The following is a description of a gene set: A compartment that consists of a lumen and an enclosing membrane, and is part of an organelle. studied in species Mus musculus Mouse Gene Set: GOCC_ORGANELLE_SUBCOMPARTMENT, and this is the list of marker genes: Slc35b1, Ugt1a2, AU040320, Hsd3b7, Fitm2, Vma21, Arxes1, Pik3r1 (NCBI Gene Id 328326), Alox5ap, Get1, Lmf1, Hsd3b3, Pigz (phosphatidylinositol glycan anchor biosynthesis, class Z), Cyp2a5, Marchf8, Ergic3, Eif2ak3, Vps53, Cyp1a1, Arfip1, Pheta1, Igf2r, Alg2, Emc6, Mtdh, Cyp2c55, Trappc6a, Faxdc2, Trappc9 (trafficking protein particle complex 9), Tbc1d23, Pi4k2b, Pip4k2b, Ptgs2, Pnldc1, Vrk1, Rpl27, Trex1, Hmox1, Golga2, Uba5, Rdh16, Agpat2, Tmed5 (NCBI Gene Id 74336), Atp8b1, Hpn, Dop1b, Ugt1a6a, Fads2, Atp6ap1, Clvs1, Sacm1l (NCBI Gene Id 83493), Disp3, Abhd12b, Rab11fip3, Fut2, Pacsin3, Ergic1, Gbf1, Cybc1, Slc37a2, Dhcr24, Por, Chrm3, Pmel, Sgpp1, Lgr5, Cyb5rl, Hsd17b3, Traf3ip3, Rab29, Slc9a7, Slc18a1, Vrk2, Pkmyt1, Cyp2c38, Cyp4a10, Gcc2, Kpnb1, Cyp7b1, Trim59, Alg12, Slc11a2, Mbtps2, Cherp, Stimate, Pomgnt2, Reep4, Mr1, Pja2, Rtcb, Pigo, Nat8f4, Sec11a, Sar1b, Tbc1d20, Dlg1, Hacd2, Or10j5, Cyp4a14, Ap3s1, Iigp1, Reep6, Zdhhc6, Rab31, Tmem50b, Rtp1, Gnai3, Dnajc1, Hace1, Akap6, Mgst1, Ext1 (exostosin glycosyltransferase 1), Mbtps1, Ttyh1, Jagn1, Sec31a, Rft1, Sec23a, Vapb, Cyp17a1, Snx9, Gpat4, Clip3, Rab38, Ap1s3, Inpp5e, Gba2, Tm7sf2, Smpd5, Gdpd1, Atxn3, Yipf6, Plpp7, Ap1g1, Parp6, Cog3, Retreg1, Sec61bl, H2-Q7, Stt3b, Otulinl, Sgk1, Eif5a, Slc37a1, Arhgap32, F830016B08Rik, Tmc6, Ei24, Preb, Icmt, Syvn1, Gimap3, Rab9, Tmem63c, Slc37a3, Ndst1, Gga1, Rnf139, 9930111J21Rik1, Lyset, Arl6ip1, Mlec, Atp8a2, Cers6, Ptgs1, Zdhhc12, Lman1l, Uchl1 (NCBI Gene Id 97283), Tmcc1, Slc27a1, Stard3, Rnf19b, Slc30a5, H2-T23, Rab2a, Sec1, Cyp2e1, H2-D1, Tmem201 (NCBI Gene Id 52277), Zfyve1, B4galt7, Aldh3a2, Irag2, Rheb, Frrs1l, Erlin1, Atp8b5, Scamp3, Rgs20, Bace1, Lss, Cdipt, Rab2b, Reep5, Bnip3, Golph3l, Cideb, Eva1a (NCBI Gene Id 232146), Galnt3, Mob4, Rhbdf1, Sts, Alg3, Ica1, Pld6, Lman1, Alg10b, Nat8f2 (NCBI Gene Id 93673), Ihh, Emd, Pnpla8, Pign, Adam10, Nucb1, Lyz1, Ndrg4, Tmem43, Kdelr3, Ubxn8, Fmo1, Atp8b4, Rnf133, Hhatl, Wdr11, Tmem87a, Dpy30, Or5b21, Agpat1, Cftr, Cdh1, Tmed1, Hsd3b4, Gramd1b, Bax, Tmcc2, Fut1, Fzd9, Ssr4, 4930568D16Rik, Sptssa, Ms4a7, M6pr, Dgat2l6, Nagpa, Derl3, Ufl1, Rnf26rt, Card19, Ksr1, Yipf1, Ermp1, Bscl2, Gpr89, Lpin2, Klhl41, Pln, 5730455P16Rik, Mrln, Dnaaf6, Slc35b2, Fkbp1a, Slc35d1, Mmp23, Kdelr2, Fut11, Kdelr1, Yipf4, Ptdss2, Sik2, Flrt3, Atg9a, Rps28, Pigk, Arfgef2, Osbp, Pacsin1, Flrt1, Saraf, Cyb5r3, Arl5c, Lyz2, Cyp2d11, Tmem14a, Slmap, Art1, Gm5431, Rnf185, Sec61g, Erlin2 (NCBI Gene Id 97480), Nos1ap, Rpn2, Mrap, Mgat4b, Acsl3, Degs1, Oas1b, Zdhhc20, Alg13, Tmem178, Pnpla6, Dgat1, Usp17lb, Pdia3, Aftph (NCBI Gene Id 75762), Golga1, Rint1, Tmem199, Tapbp, Sigmar1, Dnaaf6rt, Ms4a6c, Pcyt1a, Plod3, Tmem129, Rnf125, Chst5, Tespa1, Tspo2, Pkd2, Pcsk5, H2-T3, Cimap3, Retsat, Ntsr2, Slc9a8, Oca2, Cyp2c37, Egfr, Dhcr7, Nploc4 (NPL4 homolog, ubiquitin recognition factor), Cds1, Mgat4a, Usp17lc, Ccdc47, Calr3, Abcb6, Bicd1 (BICD cargo adaptor 1), Sez6l, Gm12185, Bet1l, Ube2j1, Cyp1a2 (NCBI Gene Id 13077), Atp13a4, Ugt1a1, Tmem119, Zdhhc14, St3gal1, Atp2a1, Cyp7a1, Atp6ap2, Gpsm1, Atp7b (NCBI Gene Id 11979), Jkamp (NCBI Gene Id 70280), Saysd1, Spcs2, Atp8b3, Tmem41b, Slc39a13, Golga3, Rab30, Grin2b, Golph3, Pacsin2, Cyp2d9, Pigl, Ncln, Ern2, Dpagt1, Dhh, Rnf183, Srd5a1, Tmem38b, Rdh19, B4galt6, Ap3b2, Hmgcr, H2-Q6, Flvcr2, Cyp2d10, Vkorc1l1, Dpy19l3, Atp13a1, H2-Q4, Tmem151a, Slc36a2, Csgalnact2, Sec11c, Tap1, Lclat1, Izumo1, Hook2, Esyt3, Extl2, Cnih1, Tgfbi, Mapkap1, Fdft1, Znrf4 (NCBI Gene Id 73546), Vps13c, Ssr1, Nr3c2, Fmo2, Rpe65, Spink5, Dipk1c, Sec22c, Epm2a, Zdhhc1, Tmed9, Selenot, Gga2, Ktn1, Yif1b, Gosr1, Hspd1, Slc33a1 (NCBI Gene Id 99713), Rps29, Prkd1, Vamp4, Vps51, Tmem86b, Akap9, Slc27a5, Arfip2, Reep3, Ankrd13c, Scd4, Pdzd8, Ap1s1, Snap25, Clcn4, Atp7a, Dnajc16, Tkt, Arf1, Galnt2, Cyp4f39, Dad1, Ankle2, Suco, Nfe2l1, Ormdl2, Sort1, Neu4, Mgst2, Mboat2, Rac1, Pcsk1, Slc17a3, Ncstn, Pitpnm1, Rab27b, Emc1, Stx16, Txndc11, Cept1, Serp1, Car4, Asph, Atp10d, Gramd1a, Aadac, Fads2b, Tmem147, Alg8, Lnpk, Zc3h12a, Tmem98, Atp2c2, Atp10a, Agpat5, Tmem79, Cyp2b19, Scamp4, Gba1, Reep2, Lypla2 (NCBI Gene Id 26394), Tgoln1, Pofut2, Tmem230, Tecr, Tgtp1, Bcap29, Slc10a7, Mboat7, Tmem260, Pigf, Dcstamp, Dgat2, Sc5d, Chpt1, Or7a40, Srebf1, Tepsin, Nsfl1c, Hid1, Clgn, Mymx, Kif13a (kinesin family member 13A), Atp8a1, Stard3nl, Cspg5, Scfd1, Lmbr1l, Jph1 (NCBI Gene Id 57339), Ap4s1, Ano5, Irgm1, Tmprss3, Rasgrf2, Cd2ap, Hsd17b12, Bace2, Get3, Plekhj1 (pleckstrin homology domain containing, family J member 1), Arl5b, Glg1 (NCBI Gene Id 20340), Extl1, Tpte, Agmo, Awat1, Mgat2, Ostc, Fate1, St3gal3, Sppl2c, Fam91a1, Rdh1, Zfand2b, Afg2b, Pigw, Cyp2c39, Pcsk7, Becn1, Slc8a3, Piezo1 (NCBI Gene Id 234839), Lrit1, Shisa2, Cyp4f14, Atp11a, Smim14, Rtn4, Elovl6, Psen2, Slc35b3, Dipk1b, Ubxn1, Tmx1, Dhdds, Piga, Ugt1a7c, Plpp2, Shisa3, Mospd2, Scd2, Tmem68, Minar2, Arv1, B4galt5, Fmo5, Usp19, Tram1l1, Hsd3b1, Cln3 (CLN3 lysosomal/endosomal transmembrane protein, battenin), Pigt, Ptgis, Scoc, Mgat4d, Acsl5, Ilvbl, Rnf43, Lrit3, Cers3, Hsp90b1, Ryr2, Spcs3, P2rx6, Ap3d1 (NCBI Gene Id 11776), Pml, Pdcd6, Osbpl3, Slc30a6, Plekha3, Dtnbp1, Fa2h, Osbpl8, Abcd4, Chpf, Clcc1 (chloride channel CLIC-like 1), Grn, Cisd2, Xxylt1, Ctdnep1, Agtrap, Gpaa1, Tom1l1, Myrf, Dnajb12, Tmed11, Calr, Msmo1, Ocrl, Irgm2, Nsg1, Zdhhc16, Sgpp2, Nat8l, Mia3, Ufd1, Cyp21a1, Emc4, Selenok, Ubiad1, Sgms1, Rnf26, Tmem258, Stim1, Panx3, Rab18, BC016579, Smim6, Sec24a, Pld5 (NCBI Gene Id 319455), Hacd1, Fut10, Gsap, Gal3st3, Grin1, Emc3, Slc2a4, Csgalnact1, Ddrgk1, Tmem174, Rtn3 (reticulon 3), Fmn1, Klhl14, Cers2, Ap4m1, Uba1, Rab3gap1, Bsg, Mogat1, Faf2, Parp16, Sting1, Selenos, Rpn1, Alg9 (NCBI Gene Id 77986), Rnf170, B4galnt4, Psen1, Fkbp1b, H2-Q1, Ero1a, Rdh9, Samd8, Trappc4, Clstn2, Sulf1, Ift88, Sqle, Ubxn4, Jph3, Atf6b, Ric3, Cyp2c29, Ugt3a1, Scamp1, Pik3c2a, Cln8, Hmgcll1, Map3k5, Hsd17b7, Pld1, Ap4b1, Tmem109, Mblac2, Tmc8, Nat8, Aldob, Maco1, Tpst1, Acer1, Fads3, Cpt1c, Myrfl, Tmed2, Sorl1, Grm6, Tmbim4, Itpr1 (inositol 1,4,5-trisphosphate receptor 1), Cers4, Scamp2, H2-Q2, Rce1, Cyp2j5, Tram2, Cpd, Myorg, Atp2a2, Stx8, Cyp26b1, Rps26, Ap1b1, Tgtp2, Wipi1, Slc30a1, Cyp3a41a, Ern1, Ccdc186, Notch1, Extl3, Aup1, Sec31b, Emc8, Tmed10, Cyp2c54, Arfrp1, Tmx3, Cyp3a25, Vmp1, Gm12250, Atp2a3, Atxn2 (ataxin 2), Pld4, Pitpnb (NCBI Gene Id 56305), St6gal1, Awat2, Erg28, Sec61a2, Cyp3a16, Apoo, Dnajb2, Srd5a2, Tmem238l, Nbea, Pex16, Slc27a6, Eda (NCBI Gene Id 13607), Hacd3, Cnih4, Tmem165, Marchf4, Ugt1a9, Nomo1, Elovl2, Sec63, Nucb2, Chst2, Jph4, Fads1, Inpp5k, Prss56, Ost4, Dmpk, Atp9a, Rnf180, Ergic2, Cd74, Marchf5, Ubqln4, Tmed3, Phtf1, Yipf5 (NCBI Gene Id 67180), Dnm2, Vps54, Bet1, Lpin1, Dhrs7, H2-K1, Sec16a, Slc39a9, Bsn, Atg14, Zdhhc2, Dnajb14, Cyp4v3, Yipf2, Cyp4b1, Ephx1, Dhrs9, Tram1, Cyp3a44, Cyp8b1, Creb3l4, Peds1, Trdn (triadin), Scap, Tmem106c, Bltp2, Usp17le, Tex2, Mmp27, Zdhhc9, Atg9b, Tmem208, Mapk8ip1, Tmed6, Slc35g1, Osbpl6, Cyp2c50, Dpy19l1, Rnf145, Gimap1, Slc39a1, Gramd2a, Pcsk4, Fmo3, Cyp4a12b, Stx18, Hsd3b6, Tlr9, Tab1, Panx2, Nat8f1, Jph2, Sln, Bok, Dhrs7b, Acsl4, Ddost (NCBI Gene Id 13200), Vapa, Ap1s2, Hhat, Or2c1, Pgap2, Lman2l, Tapbpl, Pigyl, Tapt1, Rdh10, Gper1, Prepl, Atp2c1, Zfyve27, Serac1, Gdpd3, Tmtc2, Slc27a2, Vamp2, Tm4sf20, Ebp (NCBI Gene Id 21660), Fmo4, Ero1b, B4galt3, Tas2r118, Abhd12, C2cd2l, Sec16b, Asap2, Arl6ip5, Trappc6b, Lmf2, Pam, Gabbr1, Xylt1, Slc51a (solute carrier family 51, alpha subunit), Gal3st2, Tmx2, Soat1, Srprb, Arxes2, Arap1, Psenen, Ckap4, Fut8, Rab21, Fut7, Lbr, Cyp2a12, Xbp1, Marchf9, B4galt2, Serp2, Plekha8, Necab3, Pigh, Ssr2, Cyp2c40, Cyp2b9, Rab32, Atg2a, Tex264, Cyp2d26, Chid1, Slc39a7, Baiap3, Sri, Insig2, Pclo, B3galnt2, Dop1a, Man1b1, Pigq, Plk3, Cyp2r1, Mogs, Map3k7, Acsl6, Tmem132a, Rrbp1 (NCBI Gene Id 81910), Taar1, Pld2, Birc6, Tmt1b, Nmnat2, Retreg3, Alg11, Itpr2, Pafah2, Rasip1, Slc27a4, Ch25h, Frey1, Pi4k2a, Lamp2, Sgpl1, Pigc, Ap1m1, Fut4, P4htm, Dio1, Vti1b, Gosr2, Sdcbp, B2m, Dolk, Pom121, Rnf121, Gga3, Cyp19a1, Asap1, Phaf1, Yif1a, Pyurf, Eef1a2, Pigp, Steep1 (STING1 ER exit protein 1), Elapor1, Reep1, Rab7b, Sec22a, A3galt2, Scd1 (NCBI Gene Id 20249), Rab13, B3galt6, Cyp2a4, Usp17ld, Scamp5, Sptssb, Gm4841, Atp9b, Flna, Abcb9, Hsd11b1, Rp9, H2-Q10, Pskh1, Strit1, Panx1, Pigs, Cnst, Hacd4, Gulo, Clstn1, Rnf186, Drd1, Arl1, Pgap1, Cyb5r2, Caln1, Alg6, Ptpn1, Tmem33, Dpm2, Usp17la, Lrrc8e, Mmgt2, Slc66a2, Vps13b (vacuolar protein sorting 13B), Slc26a9, Iigp1c, Tmem87b, Dio2 (deiodinase, iodothyronine, type II), Sec23b, Dnajc18, Clvs2, Svip, Ece2 (endothelin converting enzyme 2), Pigg, Ugt2b5, Cyp2c70, B4galt1, Duoxa1, Cnih2, Cltb, G6pc2, Esyt2, Elovl3, Lman2, Nat8b-ps, Ptchd3, Bcap31, Sel1l, Pnpla7, Alg1, Wfs1, Cyp3a11, Dhrs7l, Magt1, Sys1, Fkbp8, Caml, Cyp51, Cdk5rap3, Cog2, Sec22b, Creb3l2 (cAMP responsive element binding protein 3-like 2), Ier3ip1 (immediate early response 3 interacting protein 1), Myo18a, Dnajc14, Arl5a, Tgfb2, Ggta1, Zdhhc4, Cracr2a, Pnpt1, Atl1, Cyp39a1, Insig1, Xk, Jsrp1, Kcna2, Fut9, Vcpip1, Ugt3a2, Rab5if, Creb3, Llgl1, Abcc12, Slc9a6, B3glct, Pomt1, Use1, Pomt2, Tunar, Sar1a, Chac1, Rdh5, Emc10, Yipf7, Plpp6, Wdr83os, Gucy2c, Napepld, St3gal2, Pi4kb, Atl3, Tex261, Stx17, Pigu (NCBI Gene Id 71347), Stt3a, Epm2aip1, Ftcd, Creb3l3, Agpat4, Vti1a, Rtn2, Arfgef1, Aqp11, Tor1a, Nrros (negative regulator of reactive oxygen species), Igtp, Unc93b1, Alg14, Acer3, Rab14, Tmem39b, Bltp1, Galnt1, Cyp2c23, Fzd6, Cit, Scara3, Srd5a3, Cyp2s1, Tmem86a, Clptm1l, Golim4, Mest, G6pc3, Ikbip, Pemt (NCBI Gene Id 18618), Pla2g4c, Rab34, Rtp2, Ptdss1, Atp8b2, Tmem97, Tlr3, Syt11, Vamp5, Flrt2, Relch, Atp11c (ATPase, class VI, type 11C), Slc35d3, Gramd1c, Nat8f5, Fxyd3, Pomk, Aqp2, Shh, Cabp7, Uso1, Marchf2, Rnf41, Hsd3b5, Aqp8, Atl2, Rasgrp1, Rnf5, Emc2, B4galnt3 (NCBI Gene Id 330406), Pigb, Pick1, Sgms2, Ap1g2, Smim30, Chst4, Atf6, Atp10b, Creb3l1, Spast, Nsdhl, Gh, Rab11a, Sppl2b, Cyp3a13, Canx, Pigm, Rnf144a, Fitm1, Surf4, Zdhhc22, Tjap1, Mfsd2a, Erap1, Pld3, Parp8, Selenoi, Duoxa2, Plaat3, Ptges, Nat8f6, Rhbdf2, Lap3 (leucine aminopeptidase 3, NCBI Gene Id 66988), Cby1, Rictor, Upk3a, Nus1, Ppp1r15a, Prkn, Coro7 (NCBI Gene Id 78885), Erp44, Sptlc2, Selenon, Trpm1, Cyp2b10, Tmem35a, Srl, Lrrc8d, Sulf2, Mlana, Nsg2, Tmem59, Bfar, Hrc, Amfr, Dse, Slc35b4, Gabarapl2, Ebpl, Mboat1 (NCBI Gene Id 77678), Faah, Stim2, Casp4, Ubac2, Srpra, Tmem259, Ptgfrn, Eif5a2, Ddn, Rab1a, Sppl3, Pgrmc1, Smpd4, St6gal2, 1810037I17Rik, Dpm3, Mrap2, Rnf103, Tmem170, Slc27a3, Armc10, Ifi47, Dst (NCBI Gene Id 98718), Golga7, Abo, Hspa5, Cyp4f18, Hmox2, Sptlc1, Zw10, Ghitm, Dpm1, Mia2, Rab6a, Sec61a1, H13, Tlr7, Ildr2, Uxs1, Bpnt2, Ap3s2, Gnas, Syne2, Fam8a1, Camk2g, Faf1, Emc7, St3gal4, Or8a1, Gcnt1, Sel1l2, Slc30a7, Cyb561d2, Itpr3, Stbd1, Trim13, Derl1, Marchf6, Casq1, Gucy2e, Ormdl1, Postn, Azin2, Tpst2, Tmem203, Gdpd5, Mogat2, Lmbrd1, Esyt1, Tmem38a, Pgs1, Agpat3, Sec13, Cyp26a1, Traf2, Dnajc25, Slc43a1, Man2a1, Nat8f3, Plod2, Crhr1, Retreg2, Cyp2j6, Tm6sf2 (NCBI Gene Id 83488), Gpr108, Atg2b, Tmcc3, Eipr1, Cds2, Camk2d (calcium/calmodulin-dependent protein kinase II, delta), Nos1, Spcs1, Clasp2, Fkbp2, Camk2b, Marchf1, Mme, Triqk, Rsad2, Smpd3, Calhm1, Syt17, B3gat1, Ssr3 (NCBI Gene Id 99923), Porcn, Fmn2, Mboat4, Lrrc8b, Lctl, Cers1, Cdkal1, Pigx, Ldaf1, Mmp24, Tap2 (NCBI Gene Id 21355), Stx6, Edem1, Fcmr, Pgap3, Anks4b, Elovl7, Nat8f7 (N-acetyltransferase 8 (GCN5-related) family member 7), Calu, Tusc3, Ube2j2, Osbpl5, Degs2, Rab10, Cyp4x1, Gorasp2, Rho, Vcp, Bnip1, Dipk1a, Dennd5a, Hsd17b2, Cyp4a12a, Sppl2a, Abcd1, Rnf13, Clstn3, Lpgat1, Myo1b, Tmbim6 (NCBI Gene Id 68309), Ap3b1, Calr4 (calreticulin 4), Ms4a6d, Cyp1b1, Sptlc3, Soat2, Cyp2u1, Ap1m2, Golt1a, Acsl1, Ficd, Sec61b, Pcsk1n, Wls, Zmpste24, Lpcat1 (lysophosphatidylcholine acyltransferase 1), Slc24a5, Lrat, Elovl1, G6pc1, Ext2, Mospd1, Herpud1 (homocysteine-inducible, endoplasmic reticulum stress-inducible, ubiquitin-like domain member 1), Lrrc8c, Rbfox1, Derl2, Cyp2f2, Elovl4, Gsg1 (germ cell associated 1), Cant1, Slc37a4, Sdr16c5, Aph1a, Hpd, Tmem39a, Lpcat2, Tmem94, Golga5, Dolpp1, Optn, Ltc4s, Clba1, Srebf2, Tmem115, Vps13a, Emc9, Rhbdd1, Bcl2, Tlcd3b, Ms4a6b, Tyro3, Lpcat4, Abcg1, Tmem67, Gramd4 (NCBI Gene Id 223752), Nsf, Ccdc91, Acp3, Lrrc59, Rtn1, Furin, Cyp46a1, Cyb5r1, Cyb5a, Tmem214, Gnrh1, Lrrk2, Tbxas1, Alg5, Tmco1, Sez6l2, Pigv, Ryr3, Grin3b, Ptpn5, Sec62, Mtor, Abca17, Kdsr, Lpcat3, Gria1, Mmgt1, Rdh16f2, Klhl20, Krtcap2, Serinc1, Nox4, Gpat3, Moxd1, Tmed4, Ubxn7, Ryr1, Gpam, Ap4e1, Plod1, Cyp3a41b, Mctp1, Dnmbp, Stx4a, Plpp3, Gpr37, Ormdl3, Grip1, Elovl5, Vkorc1, Otof, Has2, Scd3, Dpy19l4, Hsd3b2, Rdh11, Cd4, Tmx4, Cers5, Pheta2, Dhrs7c, Slc16a11, Lrba, Anxa7, Nup210, Chsy1, Chsy3 (chondroitin sulfate synthase 3), Ggcx, Shisa5